Given this list of marker genes SEPTIN1, KNL1, ZWINT, CENPC, MLH1, here is a description of the gene set: Human Gene Set: GOBP_MEIOTIC_METAPHASE_CHROMOSOME_ALIGNMENT studied in species Homo sapiens A chromosome localization process whereby chromosomes are positioned in a specific order and orientation at the metaphase plate (spindle equator), during meiotic chromosome segregation. This alignment ensures that each daughter cell will receive the correct number of chromosomes during cell division.